Given this list of marker genes TAC1, DEFA4, VIP, PLA2G1B, EVPL, KLK7, H2BC12L, ANG, IGHA2, APP, WFDC11, SPON2, DEFA5, IGHA1, SEMG2, IGHG1, IGHD, BPIFA1, KLK3 (NCBI Gene Id 90446), PLA2G6, SEMG1 (semenogelin 1), WFDC10A, FGB, H2BC11, RPL39, HLA-E, JCHAIN, IGHG2, IGHE, WFDC12, MMP7, FGA, IGKV3-20, H2BC10, IGHM, NPY, KLK5, H2BC6, IGHG4, SLPI, LTF, PI3 (NCBI Gene Id 5266), RNASE2, H2BC4, ADM, HLA-A, B2M, SPRR2A, H2BC7, WFDC10B, LGALS4, FAU, TF, RNASE3, H2BC8, WFDC3, WFDC2, PGC, H2BC12, ELANE, RNASE6, DEFA1B, RNASE7, SPINK5, DEFA1, WFDC9, IGHG3, H2BC21, BPI, DEFA6, CAMP, DMBT1, WFDC13, CTSG, DEFB1, CALCA, DEFA3, WFDC5, RNASE4, here is a description of the gene set: An immune response against bacteria mediated through a body fluid. Examples of this process are the antibacterial humoral responses in Mus musculus and Drosophila melanogaster. Human Gene Set: GOBP_ANTIBACTERIAL_HUMORAL_RESPONSE species: Homo sapiens